Given this list of marker genes MLX, PRPF38A, CNN3, NRIP1, NCOA1, RCAN2 (regulator of calcineurin 2), NHLH2, CHMP7, PDE4D, PFN2, ZCCHC2, TMEM263, DCAF11, NFKBIZ, WDR26, EPHA3 (NCBI Gene Id 2042), ACTR3, FBXW7, CPN1, AKIRIN1, NAV3, C6orf120, CEP85, CD83, NPM1, PDSS2, CREM, SLC26A9, CREBBP, FANCI (FA complementation group I), C7orf25, CEBPA, MIER1, VGLL4, YTHDF3, CPEB3, ADGRL1, YBX1 (Y-box binding protein 1), SLC2A1, PCDH19, ZBTB44, VIRMA, CDK13, RAI1, YWHAB, STC1, CCDC140, CALCA, TOPORS, LIFR, CAB39, ZFP91, ATP1A1, ADNP, SYNGAP1, RPGRIP1L, ARHGAP6, AGO2, SATB2, NRXN3, SIAH1 (NCBI Gene Id 6477), here is a description of the gene set: Human Gene Set: TATCTGG_MIR488 Genes having at least one occurence of the motif TATCTGG in their 3' untranslated region. The motif represents putative target (that is, seed match) of human mature miRNA hsa-miR-488 (v7.1 miRBase). species: Homo sapiens